The following is a description of a gene set: from publication Doering TA, Crawford A, Angelosanto JM, Paley MA, Ziegler CG, Wherry EJ (PMID 23159438) Genes down-regulated in CD8 T effector cells at day 8 of chronic infection: LCMV-Armstrong versus LCMV-Clone 13. During acute viral infections, naïve CD8+ T cells differentiate into effector CD8+ T cells and, after viral control, into memory CD8+ T cells. Memory CD8+ T cells are highly functional, proliferate rapidly upon reinfection and persist long-term without antigen. In contrast, during chronic infections, CD8+ T cells become “exhausted” and have poor effector function, express multiple inhibitory receptors, possess low proliferative capacity, and cannot persist without antigen. To compare the development of functional memory T cells with poorly functional exhausted T cells, we generated longitudinal transcriptional profiles for each. Human Gene Set: GSE41867_LCMV_ARMSTRONG_VS_CLONE13_DAY8_EFFECTOR_CD8_TCELL_DN studied in species Homo sapiens, and this is the list of marker genes: SLC9A5, SLAMF9, TSPAN4, TMTC3, ANKRD26, NUDT17, ETS2, GOLM1, FBXW7, FBXL17, PMP22, TXNDC17, PDXP, ATP6V0E1, NR5A2, EIF3F, CDK2AP2, RFNG, STMN1, CDC42BPG, MRPS17, MRPL20, C1orf198, NFXL1, CD36, DKC1, GCN1, ATP6AP2, MPHOSPH9, TXLNA, IRF2BP1, UNC119B, ZNF280B, MTA1, TSPAN6, BCL7A, UQCR10, ATP5MG, AKAP1, DVL1 (NCBI Gene Id 348497), DNMT3B, ABHD13 (NCBI Gene Id 84945), GALK1, CEP43, C5orf24, TIAM1, PHOSPHO1, TMEM121 (transmembrane protein 121), DCBLD2, ARID2, CNOT9, SRF, ENO4, MTMR4, LAGE3, SCMH1, POU2F1, POLR2C, CCDC83, GPX4, EIF2B4, HM13, KTI12, RAB43, AKT2, ARL5B, PHLDA1, ZRANB2, BRAF, ADAM19, SH2D1B, MOB3A, RRM2, CAMK2N2, ZW10, EMC4, CRY1, EPS8, DESI2, STAT5B, PIGO, ITPRID2, AKR7A2, LHPP, KDM1B, GCSH, SLC25A6, ABHD14B, TTC16, DHX33, EDEM1, C16orf95, XYLB, HES1, DENND5A, VCL, KIAA0930, EEF2K, PLPP2, ABHD17A, DESI1, SLPI, NOMO1, MRPL4, DUSP14, FASTKD3, GBGT1, ANGPTL4, ZNF22, GFUS, EAF2, AHR, KLF9, DIP2A, STAM2, CEP97, IRF4, NCKIPSD, YIF1B, RYR1, TEKT1, TMEM147, SP1, MFSD6L, SNRPB, TPRN, NEU1 (neuraminidase 1), PLA2G6, FOXO4, MZT2B, BAG4, GCOM1, CNOT7, TSPAN2, MZF1, BHLHE40, EPS15, NAB1, YTHDF1, SYDE1, POLR3G, RAI1, EML3, FAM241A, ORC6, HNRNPC, UBR5, SLC39A10, SEC11C, SNX3, MKNK2, SLC12A4, FZD2, ORMDL3, ANKRD13A, ZFP36L2 (NCBI Gene Id 96706), ELL2, DNPH1, INAFM1, CREB3L2, NIFK, ARMCX6, ISCU, UQCR11, CNOT6L, RCHY1, RPRD1B, NABP1, PFN2, POLR2I, SUCLG1, ABCG2, VPS26B, RNF103, SLC25A39, CIAO2B, KPNA1, MRPS26, HACD2, AHSP, TPRA1, ELOVL6, GLI2, RPIA, COMT, TTC7A, CRELD1, ARHGAP36, ATP8B2 (NCBI Gene Id 57198), TNFAIP8L1, AZIN1, DGKH, ECE1, ZMYM2, PYCR3, MCM7, BASP1, LINGO3, C1QBP (NCBI Gene Id 708), PIM2